Given this list of marker genes EIF4E2, CYTIP, NEDD8, DLK1, IFI6, TRAIP, RBPMS, KYAT3, CFLAR (NCBI Gene Id 8837), LDHA (NCBI Gene Id 3939), STX1A, B4GALT5, PRSS23, PRP4K (pre-mRNA processing factor kinase PRP4K), PTP4A2, GADD45G, CD247, RSRC2, MUSK (muscle associated receptor tyrosine kinase), RAB36, UCP2, H6PD, SLC6A8, SKP1, PDE1A, OIP5, EIF1AY, CTSL, RHCE, HMGN3, VCAM1, BPI, SOD3, SLC39A8, MTHFD2, FGL1, FUT2, GPR3, GPR35, NDUFAF3, NEDD9, GPD1, ITFG2, TNFAIP8, IL1RN, CHST2, DMXL2, PROZ, MPZL1, AFAP1, GREB1 (growth regulating estrogen receptor binding 1), MMP9, ZHX2, TMPRSS6, RBM12, MAP2K1, PLAUR, IDUA, CDK17, CDK16, GOLGA4, KIF2A, ATP6AP1, IDO1, CCL3, MARCKSL1, CNOT9, CLPP, HMMR, SLC11A2, CENPI, TECPR2, DUSP5, CYTH2, WTAP, HCAR3, KRAS, KEL (NCBI Gene Id 3792), SPI1, ATMIN, CXCR4, MT1E, TNFAIP3 (TNF alpha induced protein 3), SNTB1, ZNF268, GRIN2C, ACR, P2RX4, CFP, FZD6, ICAM1, KCNV2, PDE8B, EFNA4, ACSL1, S100A11, EFR3B, TNFAIP2, EZH2, NBN, PHACTR1, SLURP1, LORICRIN, OPTN, PNLIPRP2, CDKN2D, PDZK1, NF2, SENP3, APOC3, CLCNKA, TPPP, HLA-DQA1, CELF3, CRISP1, PRPH, PSMD8 (proteasome 26S subunit, non-ATPase 8), RFX2, TAGLN3, VRK2, VPS13B, PLXNC1, KIFBP, DESI1 (desumoylating isopeptidase 1), KLRD1, ARAF, MSC, CDKN1A, AQP9, MLH1, ANKRD46, ANKRD7, IGF2, PRKD3, HBEGF, SF3B1, GLOD4, HBE1, ADRA2A, FSCN1, HIBCH, LILRB5, PRSS8, SYN1 (NCBI Gene Id 6853), TNFRSF1B, LOXL1 (lysyl oxidase like 1), JAK1, PHLDA2, ZKSCAN1 (zinc finger with KRAB and SCAN domains 1), STOM, ETS2, SRPX (NCBI Gene Id 8406), FAM89B, MT2A (NCBI Gene Id 4502), BTG3, TRAF1, NFKBIA, MPZ, PPIL2 (NCBI Gene Id 23759), RGS1, RNF115, G3BP2, CNOT3, ARHGEF12, PTGER2, CDK5R1, CLK2, SCAND2P, UGCG, TNR, PDAP1, LAMP3, DDX51, MUC5B, RGS16, RCAN1, RELA, CLDN4, IRS2 (NCBI Gene Id 90066), ATP9A, SRY, LMF2, QSOX1, IER3, VAMP5 (NCBI Gene Id 200553), AMPD3 (NCBI Gene Id 272), CHD1, CASC3, RHOBTB3, TRPC2, MED7, UBE2D1, SAT1, CDX2, LRRN2, HNRNPM, NPAS2, BASP1, PCM1, CST7, here is a description of the gene set: Human Gene Set: GSE360_L_MAJOR_VS_B_MALAYI_HIGH_DOSE_DC_UP from publication Chaussabel D, Semnani RT, McDowell MA, Sacks D, Sher A, Nutman TB (PMID 12663451) species: Homo sapiens Monocyte-derived dendritic cells (DC) and macrophages (MΦ) generated in vitro from the same individual blood donors were exposed to five different pathogens, and gene expression profiles were assessed by microarray analysis. Responses to Mycobacterium tuberculosis and to phylogenetically distinct protozoan (Leishmania major, L. donovani, Toxoplasma gondii) and helminth (Brugia malayi) parasites were examined, each of which produces chronic infections in humans yet vary considerably in the nature of the immune responses they trigger. Genes up-regulated in comparison of dendritic cells (DC) exposed to L. major versus DCs exposed to 50 worms/well B. malayi.